Given this list of marker genes NEDD9, CDH13, CCN2, PDLIM1, CDH6, ITGA3, MMP2 (NCBI Gene Id 4313), TFPI2, MMP3, TPM2, SPOCK1, SPP1, ELMO1, MYO10, FSCN1, here is a description of the gene set: from publication Mahadevan D, Cooke L, Riley C, Swart R, Simons B, Della Croce K, Wisner L, Iorio M, Shakalya K, Garewal H, Nagle R, Bearss D (PMID 17325667) Human Gene Set: MAHADEVAN_GIST_MORPHOLOGICAL_SWITCH Genes up-regulated in the GIST (gastrointestinal stromal tumor) cell line resistant to imatinib that may correlate with the morphological switch in these cells. studied in species Homo sapiens KIT or alpha-platelet-derived growth factor receptor (alpha-PDGFR) activating mutations are the pathogenic mechanisms that characterize gastrointestinal stromal tumors (GIST). Despite excellent responses to imatinib mesylate (IM), patients are relapsing. We developed an IM-resistant GIST cell line (GIST-R) from the IM-sensitive GIST882 cell line (GIST-S) by growing these cells in IM. Gene expression profiling (GEP) of GIST-S, GIST-R cells and two IM resistant GIST patients demonstrated that KIT is downregulated implying a major role in IM resistance. Instead, GIST-R cells have acquired IM resistance by overexpressing the oncogenic receptor tyrosine kinase - AXL - in a 'kinase switch'. Further, the two IM resistant GIST patients express AXL and not c-Kit, seen by immunohistochemistry (IHC). Real time reverse transcriptase-polymerase chain reaction and Western blotting of the GIST-S and GIST-R cells confirmed the switch from Kit to AXL. In GIST-R, AXL is tyrosine phosphorylated and its ligand growth-arrest-specific gene 6 is overexpressed implying autocrine activation. The kinase switch is associated with a morphological change from spindle to epithelioid. Molecular modeling of the kinase domain of mutant c-Kit (V654A) and AXL showed no binding to IM but efficient binding to MP470, a novel c-Kit/AXL kinase inhibitor. MP470 synergizes with docetaxel (taxotere) and is cytotoxic to GIST cells.